The following is a description of a gene set: Genes predicted to be targets of miRBase v22 microRNA mmu_miR_7035_3p in miRDB v6.0 with MirTarget v4 prediction scores > 80 (high confidence targets). Mouse Gene Set: MIR_7035_3P studied in species Mus musculus from publication Chen Y, Wang X (PMID 31504780), and this is the list of marker genes: Mpped1, Ttbk1, Foxk2 (forkhead box K2), Tspan11, Fam168a, Rgs12, Lclat1, Dnase1l1, Uqcc6, Rmnd5a, Neurog1, Ilrun, Ppp1r3b, Ankrd13b, Zfp563, Ptbp1, Cgn, Iglon5, Cemip, Mtmr4, Dcaf4, Vangl1, Set, Opa1, Pacrg, Kpna3, Gabarap, Esrrb, Rab6b, Zfp512b, Lnx1, Amn, Ark2n, Mark2, Zfp747l1, Eif4g2, Jagn1, Cd93, Sftpd, Calhm5, Mob2, Papolg (NCBI Gene Id 216578), Nxt2, Thumpd1, Elp3, Luzp1, Dr1 (NCBI Gene Id 67362), Slc44a2, Fnip1, Heg1, Ehmt1, Actr10, Ubac2, Tomm40, Irs3, Mapk1, Lysmd4, Slc4a5, Slc7a6, Alox5ap, Zfp704, Ddo, Stx6, Smyd5, Alx1, Atg9a (autophagy related 9A), Trim25, Trp63, Gpr55, Arpp21, Tmem62, Chdh, B4gat1, Btnl9, Cep128, Plaat3, Sf3a1, Slc25a42, Chst3, Ccn4, Tenm4, Med8, Fmnl2, Ptbp2, Disp3, Pappa, Tlr7, Txlna, Tmem38a, Glrx5, Pknox1, Rnf14